The following is a description of a gene set: MET Receptor Activation Mouse Gene Set: REACTOME_MET_RECEPTOR_ACTIVATION studied in species Mus musculus, and this is the list of marker genes: Met, Spint2, Spint1, Hgf, Hgfac, Hpn